The following is a description of a gene set: studied in species Homo sapiens Any process that stops, prevents or reduces the frequency, rate or extent of intrinsic apoptotic signaling pathway by p53 class mediator. Human Gene Set: GOBP_NEGATIVE_REGULATION_OF_INTRINSIC_APOPTOTIC_SIGNALING_PATHWAY_BY_P53_CLASS_MEDIATOR, and this is the list of marker genes: BDKRB2, ING2, PRKN, RRN3, RRM2B, PTTG1IP (NCBI Gene Id 756), TRIAP1, ELL3 (NCBI Gene Id 80237), TAF9B, MIR21, KDM1A, BCL2, ZNF385A, MIF, ARMC10, CD74, MARCHF7, TAF9, SIRT1, CD44, MDM2, BCL2L12, MUC1, ATAD5